Given this list of marker genes HNRNPL, MCM6, CSNK2B, HPRT1, H2AZ1, DRAP1, U2AF1, HNRNPD, EEF1B2, SLC25A3, APRT, TRIM28, ANP32B, HMGN1, PPIA, ILF2, HMGN2, NAP1L1, KHDRBS1, NACA, EEF1G, EBP, HDAC1, MCM5, NCL, SNRPA, HNRNPA1, SNRPA1, GAMT, CLIC1, RPL11, SNRPB, EIF4B, SRSF9, FXR1, DUT, here is a description of the gene set: Human Gene Set: GCM_ANP32B Neighborhood of ANP32B acidic (leucine-rich) nuclear phosphoprotein 32 family, member B in the GCM expression compendium Neighborhood of ANP32B studied in species Homo sapiens